Given this list of marker genes PARP8, SRPK2, SRPK1, GSK3A, PARP16, SUMO1, UBE2I, PARP14, PRMT1, PARP6, PARP9, GSK3B (glycogen synthase kinase 3 beta), PARP10, CSNK1A1, PARP4, here is a description of the gene set: Human Gene Set: REACTOME_MATURATION_OF_SARS_COV_2_NUCLEOPROTEIN species: Homo sapiens Maturation of nucleoprotein